The following is a description of a gene set: Human Gene Set: GOBP_POSITIVE_REGULATION_OF_PROTEIN_EXPORT_FROM_NUCLEUS Any process that activates or increases the frequency, rate or extent of directed movement of proteins from the nucleus into the cytoplasm. studied in species Homo sapiens, and this is the list of marker genes: YWHAE (NCBI Gene Id 7531), RBM22, MDM2, ANP32B (acidic nuclear phosphoprotein 32 family member B), IL1B, BAG3, PPM1A, PRKACA, PRKD1, CTDSPL2, XPO4, SIRT6, PRP4K, CAMK1, GAS6, GSK3B, RAPGEF3, SFN, TPR, EMD (NCBI Gene Id 2010)